Given this list of marker genes RNU4ATAC, NEB, RYR1, OPA1, LTBP4, ASH1L, FGFR3, CFL2, VARS1 (NCBI Gene Id 7407), PEX1, PTCD3, LEMD2, ERGIC1, COL1A1, PTPN23, MYH3, RRAGC, MED12, TAOK1, SLC26A2 (solute carrier family 26 member 2), GP1BB, DEF6, HNRNPK, ITGB3, DTYMK, MKS1, SERPINH1, COL25A1, ADAMTS2, MKRN3 (makorin ring finger protein 3), LMOD3, CYP11B2, ARSB, RSPRY1, SHPK, COQ4, ITGA2B, SNORD115-1, KDM3B, GP1BA, LDHA, SPTBN1, ORC1, UQCC2 (NCBI Gene Id 84300), PWAR1, CYP11B1, ATP6V0A2, SON, COL1A2, MYPN, CYP11A1, F2, ASXL3, TAF1, ITGA2, TPM3, SCN4A, SLC6A5, KLHL41, KLHL40, POR (cytochrome p450 oxidoreductase), ZMPSTE24, DST, ACTA1, ZNF699, CHD8, UBAP2L, CRTAP, ZFX, CACNA1D, MTM1, TPM2, DHCR7, HERC2, SATB1, POLR3A, SNORD116-1, IARS2, PLOD1, AGTPBP1, MTHFS, PRKAG2, PWRN1, MAGEL2, CD109, COL3A1, CDC42BPB, ACY1, COL5A1, RMRP, RBM10, AXIN1, MCM4, CHST3, HACD1, F8, NPAP1, PIGA (NCBI Gene Id 5277), KBTBD13, SCYL2, ADNP, COL5A2, EEF1A2, here is a description of the gene set: studied in species Homo sapiens An abnormality of the birth process. Abnormal delivery Human Gene Set: HP_ABNORMAL_DELIVERY